Given this list of marker genes NOD2, POMC (proopiomelanocortin), GFRAL, CARTPT, PTER, SCT, UCN, HTR4, HTR2C, GDF15, PPARA, SPX, FBN1, LEP, NPFF, GALP, SLC22A3, MKKS, SCTR, GHRL, BBS4, GHSR, NENF, BBS2, NPY, here is a description of the gene set: species: Homo sapiens Human Gene Set: GOBP_REGULATION_OF_APPETITE Any process which modulates appetite, the desire or physical craving for food.